The following is a description of a gene set: studied in species Homo sapiens Human Gene Set: GOBP_PHOSPHOLIPID_HOMEOSTASIS Any process involved in the maintenance of an internal steady state of phospholipid within an organism or cell., and this is the list of marker genes: ABCB11 (ATP binding cassette subfamily B member 11), HNF4A, LIPG, TLCD2 (NCBI Gene Id 727910), ABCA3, ABCA1, SLC25A46 (NCBI Gene Id 91137), CETP, ABCG1, RCN3, GPAM, TLCD1, ITGB6, FABP3, TGFB1, ANGPTL3, APOA1